The following is a description of a gene set: Human Gene Set: GSE40685_NAIVE_CD4_TCELL_VS_FOXP3_KO_TREG_PRECURSOR_UP Genes up-regulated in CD4: naïve versus FOXP3 knockout T reg precursors. Regulatory T (Treg) cells, whose identity and function are defined by the transcription factor Foxp3, are indispensable for immune homeostasis. It is unclear whether Foxp3 exerts its Treg lineage specification function through active modification of the chromatin landscape and establishment of new enhancers or by exploiting a pre-existing enhancer landscape. Analysis of the chromatin accessibility of Foxp3-bound enhancers in Treg and Foxp3-negative T cells showed that Foxp3 was bound overwhelmingly to pre-accessible enhancers occupied by its cofactors in precursor cells or a structurally related predecessor. Furthermore, the bulk of Foxp3-bound Treg cell enhancers inaccessible in Foxp3- CD4+ cells became accessible upon T cell receptor activation prior to Foxp3 expression with only a small subset associated with several functionally important genes being exclusively Treg cell-specific. Thus, in a late cellular differentiation process Foxp3 defines Treg cell functionality in an “opportunistic” manner by largely exploiting the preformed enhancer network instead of establishing a new enhancer landscape. studied in species Homo sapiens from publication Samstein RM, Arvey A, Josefowicz SZ, Peng X, Reynolds A, Sandstrom R, Neph S, Sabo P, Kim JM, Liao W, Li MO, Leslie C, Stamatoyannopoulos JA, Rudensky AY (PMID 23021222), and this is the list of marker genes: H2BC13, PGM2L1, CKS1B, ZNF654, SP4, SNRPA, HK2, CD200R1L, CCR2, ARSB, FSTL3, RELT, DCAF15, ILDR1, LGALS1, FOXRED1, NOL11, KCNK5, EXOC5, TMBIM1, TSHB, CD86, PRR5L, DKKL1, NFXL1, MTIF3, TMPRSS13, ITGA2, PBDC1, CHD7, RIOX2, LHFPL6, IFITM2, CALR, GUCY2D, BCL6B, ARPP19, KRT24, CREB1, MASTL, MYO1F, MYO1G, AP1G2, LGI2, SAA2, GOLM1, EHD1, MYH4, ANXA1, S100A4, COX15, CIP2A, MED7, ST14 (NCBI Gene Id 6768), TMEM238, B4GALT1, DMRTB1, MECR, NUP54, NCK2, C9orf85, TARDBP, ENKD1, SRSF12, PEDS1, SPAG5, RBPJ, GLIPR1, RIPK3, SIKE1, SLC6A1, AHNAK, TMEM14C, EPAS1, DNAJC15, CACTIN, PRR13, FASLG, WDR55, RALA, ADAM8, UTP25, TMEM218, HRH2, KLRC1, SLC39A14, PRKD3, FCGRT, ZBTB38, TSHZ1, SWAP70, CEP83, KLHL33, LAMC1, MDFIC, FAM124B, L1CAM, RIDA, CRIP1, CRYBG1, ARL5A, CYTH2, PPP3CA, ERP29, CYP2S1, DYNLL1, TIPRL, RMDN2, FCHO1, C21orf91, KBTBD3, ZSCAN20 (zinc finger and SCAN domain containing 20), SOX8, ASGR1, MT1E, TMEM225, CHSY1, SLC6A12, STT3A, VAX2, RAP1GAP2, H2AX, IL2RB, ACY1, MYOCD, NCCRP1, S1PR5, TYROBP (NCBI Gene Id 7305), EXOSC9 (exosome component 9), TBL2, DSTN, CDKN2B, SPATA16, SLC35B1 (solute carrier family 35 member B1), AKTIP, EIF2AK3, G2E3, PRKAR2A, PCMT1, USP14, TES, CD79B, CFAP119, CCL4, GRM5, FAM89B, BCL2L1, APOA4, ACTR1A, RAP1B, TJP2, SFTPB, FBXO17, FAM20A, CRY1, ZP1, GEM, CAAP1, DOHH, SV2C, OAT, PDSS1, PTPRJ, CAPG, SYCP3, UBA5, ALG8, VPS54, PRKAB1, FKBP1A, ANXA6, POLA1, ATP1A2, DLST, N4BP1, HUS1, ASB1, FKBP1B, SLCO4A1, LYZL6 (lysozyme like 6), HMGB2, TMPO, CRYZ, TST, F2RL3, HSPA8, ANP32E, CHMP5, LRRK1, NUS1, ALOX15B, SLC25A53, HAS3, BRCA2, CCND2 (cyclin D2), F2RL2, DSCC1, NQO1, CTSC, GPR65